Given this list of marker genes GOLGA2, GBF1, VRK1, STX5, CDK1, PLK3, here is a description of the gene set: A cellular process that results in the breakdown of a Golgi apparatus that contributes to Golgi inheritance. Human Gene Set: GOBP_GOLGI_DISASSEMBLY species: Homo sapiens